The following is a description of a gene set: Mouse Gene Set: GOBP_CELLULAR_RESPONSE_TO_HYDROGEN_PEROXIDE studied in species Mus musculus Any process that results in a change in state or activity of a cell (in terms of movement, secretion, enzyme production, gene expression, etc.) as a result of a hydrogen peroxide (H2O2) stimulus., and this is the list of marker genes: Sirt6, Mapk7, Bnip3, Trpm2, Setx, Src, Kdm6b, Abl1, Hspa8, Ezh2, Trpa1, Foxo1, Mapk13, Aqp1, Ednra, Ern1, Pdgfrb, Fyn (NCBI Gene Id 14360), Ankzf1, Tnfaip3 (NCBI Gene Id 21929), Cfl1, Gata5, Il6, Zfp277, Trpc6, Ripk1, Sirpa, Mapk8, Fabp1, Cdkn2a, Cyp1b1, Ripk3, Park7 (NCBI Gene Id 57320), Rela, Ngb, Fxn, Axl, Cbx8, Nqo1, Pcna, Map1lc3a, Pdgfd, Plekha1, Klf2, Rnf146, Prkcd, Hdac6, Nfe2l2, Stat6, Txn1, Becn1, Ect2, Oser1, Hdac2, Cdk1, Top2b, Zfp580, Sirt1, Sphk1, Net1, Aifm1, Akr1b1, Cat, Pcgf2, Ppif, Ppef2 (NCBI Gene Id 19023), Smpd3, Prkaa1, Hsf1, Anxa1, Lcn2 (lipocalin 2), Klf4, Edn1, Rps3, Apex1 (apurinic/apyrimidinic endonuclease 1), Capn1, Map3k5, Il18rap (interleukin 18 receptor accessory protein), Mdm2, Rhob